Given this list of marker genes Lcn2, Steap2, Iscu, Ifng, Slc39a8, here is a description of the gene set: Mouse Gene Set: GOBP_IRON_ION_IMPORT_ACROSS_PLASMA_MEMBRANE studied in species Mus musculus The directed movement of iron ions from outside of a cell, across the plasma membrane and into the cytosol.